Given this list of marker genes CASP3, HTT, CASP8, HIP1, IFT57, here is a description of the gene set: Mutation-caused aberrant Htt to extrinsic apoptotic pathway. Pathway ID: N00983. Pathway type: Variant. Pathway class: nt06461 Huntington disease. Human Gene Set: KEGG_MEDICUS_VARIANT_MUTATION_CAUSED_ABERRANT_HTT_TO_EXTRINSIC_APOPTOTIC_PATHWAY studied in species Homo sapiens Pathway Definition from KEGG: HTT* // (HIP1+IFT57) -> CASP8 -> CASP3